The following is a description of a gene set: species: Homo sapiens Human Gene Set: GOBP_LIPOPHAGY The selective degradation of lipid droplets by macroautophagy., and this is the list of marker genes: RAB7A, ADRB2, SPTLC1 (NCBI Gene Id 3302), SESN2, AUP1, HTT, SPTLC2, SPART